Given this list of marker genes PTCH1, KEAP1, SMARCB1, PTCH2, APC, PALB2, ELP1, CDKN2A, MDM2, GPR161, ASXL1, SUFU, CHEK2, TP53, DICER1, NBN, BRCA2, MLH1, CTNNB1, here is a description of the gene set: A rapidly growing embryonic tumor arising in the posterior part of the cerebellar vermis and neuroepithelial roof of the fourth ventricle in children. More rarely, medulloblastoma arises in the cerebellum in adults. Medulloblastoma Human Gene Set: HP_MEDULLOBLASTOMA species: Homo sapiens